Given this list of marker genes SLCO2B1, SLCO1B3, SLCO1B1 (solute carrier organic anion transporter family member 1B1), SLC16A2, SLCO4A1, SLCO4C1, SLCO2A1, SLCO3A1, AVP, SLCO1A2, SLCO1C1, here is a description of the gene set: species: Homo sapiens Human Gene Set: REACTOME_TRANSPORT_OF_ORGANIC_ANIONS Transport of organic anions